Given this list of marker genes Sh3bgrl, Rgs20, Ssb, Xaf1, Coa5, Cenpb, Bbip1, Eif2a, Ccdc34, Rflnb, Kif1c, Pkp4, Phldb2, Kif5b, Zeb1, Hnrnpa3, Htatsf1, Dcaf5, Inpp1, Fbxo32, Palld, Gm4836, Dynll2, Kctd10, 5730409E04Rik, Bmi1, Ddr2, Kank2, Rbis, Zbtb12, Gab2, Apc, Cyb5r3, Trp53inp2, Naa50, Dynlt3 (dynein light chain Tctex-type 3), Vcpip1, Map1b, Mff, Map2k7, Rab13, Ccng1, Samd4, Eif3e, Ppfia1, Ccnd2, Ankrd11, Septin7 (NCBI Gene Id 235072), Dkc1, here is a description of the gene set: from publication Mili S, Moissoglu K, Macara IG (PMID 18451862) Mouse Gene Set: MILI_PSEUDOPODIA species: Mus musculus Transcripts significantly enriched in pseudopodia of NIH/3T3 cells (fibroblast) in response to both chemotactic (lysophosphatidic acid, LPA) and haptotactic (fibronectin, FN1 [GeneID=2335) migratory stimuli. RNA localization is important for the establishment and maintenance of polarity in multiple cell types. Localized RNAs are usually transported along microtubules or actin filaments and become anchored at their destination to some underlying subcellular structure. Retention commonly involves actin or actin-associated proteins, although cytokeratin filaments and dynein anchor certain RNAs. RNA localization is important for diverse processes ranging from cell fate determination to synaptic plasticity; however, so far there have been few comprehensive studies of localized RNAs in mammalian cells. Here we have addressed this issue, focusing on migrating fibroblasts that polarize to form a leading edge and a tail in a process that involves asymmetric distribution of RNAs. We used a fractionation scheme combined with microarrays to identify, on a genome-wide scale, RNAs that localize in protruding pseudopodia of mouse fibroblasts in response to migratory stimuli. We find that a diverse group of RNAs accumulates in such pseudopodial protrusions. Through their 3' untranslated regions these transcripts are anchored in granules concentrated at the plus ends of detyrosinated microtubules. RNAs in the granules associate with the adenomatous polyposis coli (APC) tumour suppressor and the fragile X mental retardation protein (FMRP). APC is required for the accumulation of transcripts in protrusions. Our results suggest a new type of RNA anchoring mechanism as well as a new, unanticipated function for APC in localizing RNAs.